The following is a description of a gene set: Mouse Gene Set: ZHENG_FOXP3_TARGETS_IN_THYMUS_UP species: Mus musculus from publication Zheng Y, Josefowicz SZ, Kas A, Chu TT, Gavin MA, Rudensky AY (PMID 17237761) Transcription factor Foxp3 (forkhead box P3), restricted in its expression to a specialized regulatory CD4+ T-cell subset (T(R)) with a dedicated suppressor function, controls T(R) lineage development. In humans and mice, Foxp3 deficiency results in a paucity of T(R) cells and a fatal breach in immunological tolerance, causing highly aggressive multi-organ autoimmune pathology. Here, through genome-wide analysis combining chromatin immunoprecipitation with mouse genome tiling array profiling, we identify Foxp3 binding regions for approximately genes and for an intergenically encoded microRNA. We find that a large number of Foxp3-bound genes are up- or downregulated in Foxp3+ T cells, suggesting that Foxp3 acts as both a transcriptional activator and repressor. Foxp3-mediated regulation unique to the thymus affects, among others, genes encoding nuclear factors that control gene expression and chromatin remodelling. In contrast, Foxp3 target genes shared by the thymic and peripheral T(R) cells encode primarily plasma membrane proteins, as well as cell signalling proteins. Together, our studies suggest that distinct transcriptional sub-programmes implemented by Foxp3 establish T(R) lineage during differentiation and its proliferative and functional competence in the periphery. Genes with promoters bound by FOXP3 and which are up-regulated only in developing (located in the thymus) regulatory CD4+ T lymphocytes., and this is the list of marker genes: Fem1c, Zbtb25, Atp6v1a, Reep3 (NCBI Gene Id 28193), Hbp1 (high mobility group box transcription factor 1), Pip4k2a, Ifi208, Jarid2, Galnt4, Ptbp3, Trim34a, Tpp2 (NCBI Gene Id 22019), Dbf4, Dipk1a, Hbs1l, Hif1a (NCBI Gene Id 15251), Top1, Gbp6, Jmjd1c, Lnx2, Pvt1, Arhgef10, Dennd6a, Strn3, Psma1, Fam3c, Fli1, Map3k1, Rabgap1l, Ifnar2, Lrif1, Cd84, Ccdc32, Fam8a1, Gpr183 (NCBI Gene Id 321019), Myo9a, Cd69, Sri (sorcin), Arhgap15, Cxcr4, Top2b, Gphn, Dennd5a, Ncoa3, Nudcd3, Rfx3, Map3k5, Tnfsf11, Klf3, Cnot2, Atg16l1, Sesn1, Zfp36l2, Evi5, Armt1, Kat6b, Srsf2, Ext1, Zyg11b, Stat4, Rgs1, Arid5b, Lats2, Tbc1d15, Tnfaip3, Cdk19, Peli1, Otulin, Heatr5a, Vcpkmt, Tlr1, Tasp1, Gpr18, Fam76b, Rab8b, Cnot6l, Ubac2, Rnf125 (ring finger protein 125), Rpl5, Man1a2, Ptger2, Exoc6b, Pik3r1, Dock10, Ipcef1, Pde4b, Wbp4, Parl, Fam91a1, Nup153, Ibtk, Zbtb20, Tox, Akap13, L3mbtl3, Sgms1, Kif3b, Phtf2, Socs2, Gbp2b, Sik3, Glcci1, Sec63 (NCBI Gene Id 70585), Elk3, Nek7, Wnk1, Btbd10, Naa30, Ankrd12, Errfi1, Mdfic (MyoD family inhibitor domain containing), Zc3hav1, Nfkbiz, Tbc1d30, Pak1ip1, Inpp4b, Cdk17, Ttc39b, Cast, Gdi2, Zfand6, B3gnt2, Slc25a40, Slc37a3, Ppp2r5c, Trio, Arl4a, Elf1, Cd28, Tbc1d5, Nt5e, Rapgef6, Gprin3, Trat1, Tcf12, Herpud2, Ldlrad4, Tespa1, P2ry10, Slamf1, Cdk2, Etnk1, C2cd5 (NCBI Gene Id 77314), Ifi209, Add3, Il7r, Mtfr1, Nr3c1, F2rl1, Malt1, Dusp22, Dctn6, Zfp217, Vps54, Ppp3cc, Smc5, D16Ertd472e (DNA segment, Chr 16, ERATO Doi 472, expressed), Vopp1, Nck2, Cpox (coproporphyrinogen oxidase), Ap4s1, Klf6, Slc35b3, Wdr37, Zkscan3, Abt1, Hivep2, Asxl2, Nsmce2 (NCBI Gene Id 68501), Sla, Lta4h, Bloc1s5, AI504432, Sdcbp, C230066G23Rik, Ttc33, Mbnl1, Ids, Slamf6, Lncpint, Samhd1, Ets1, Chd9, Cpe, Cited2, Lrch1, Tubb4b, Celf2, Arhgap5, Lrig1, Itga6, Stat5b, Atp2b1, Tmem64, Esd (NCBI Gene Id 51790), Arhgef3, Trbv14, Man1a, Abtb2, Irf4, Pgap1, Cblb